The following is a description of a gene set: Mutation of the genes encoding the WNT signaling components adenomatous polyposis coli or beta-catenin plays a critical role in the initiation of colorectal cancer. These mutations cause constitutively active beta-catenin/TCF-mediated transcription, driving the transformation of intestinal crypts to colorectal cancer precursor lesions, called dysplastic aberrant crypt foci. CD44 is a prominent WNT signaling target in the intestine and is selectively expressed on the renewing epithelial cells lining the crypts. The expression of CD44 is dramatically increased in aberrant crypt foci in both humans and tumor-susceptible Apc(Min/+) mice, suggesting a role for CD44 in intestinal tumorigenesis. To study this role, we crossed C57BL/6J-Cd44(-/-) mice with C57BL/6J-Apc(Min/+) mice. Compared with C57BL/6J-Cd44(+/+)/Apc(Min/+) mice, C57BL/6J-Cd44(-/-)/Apc(Min/+) mice showed an almost 50% reduction in the number of intestinal adenomas. This reduction was primarily caused by a decrease in the formation of aberrant crypts, implying the involvement of CD44 in tumor initiation. The absence of CD44 in the normal (nonneoplastic) crypts of Cd44(-/-)/Apc(Min/+) mice did not alter the proliferative capacity and size of the intestinal stem cell and transit-amplifying compartments. However, compared with Cd44(+/+)/Apc(Min/+) mice, Cd44(-/-)/Apc(Min/+) showed an increase in the number of apoptotic epithelial cells at the base of the crypt which correlated with an increased expression of the proapoptotic genes Bok and Dr6. Our results show an important role for CD44 in intestinal tumorigenesis and suggest that CD44 does not affect proliferation but is involved in the control of the balance between survival and apoptosis in the intestinal crypt. Genes implicated in apoptosis that were up-regulated in duodenum of CD44 knockout mice. species: Mus musculus from publication Zeilstra J, Joosten SP, Dokter M, Verwiel E, Spaargaren M, Pals ST (PMID 18483247) Mouse Gene Set: ZEILSTRA_CD44_TARGETS_UP, and this is the list of marker genes: Bcl2a1b (NCBI Gene Id 12045), Htra1, Capn2, Agt, Tnfrsf21, Tnfrsf14, Bok, Tnfrsf22 (NCBI Gene Id 79202), Relt